The following is a description of a gene set: studied in species Homo sapiens Human Gene Set: GOCC_PERICENTRIC_HETEROCHROMATIN Heterochromatin that is located adjacent to the CENP-A rich centromere 'central core' and characterized by methylated H3 histone at lysine 9 (H3K9me2/H3K9me3)., and this is the list of marker genes: CBX1, DNMT1 (DNA methyltransferase 1), BAZ1B (bromodomain adjacent to zinc finger domain 1B), ATRX, CENPB (centromere protein B), CENPC, BAZ1A, IKZF1 (IKAROS family zinc finger 1), ESCO2 (establishment of sister chromatid cohesion N-acetyltransferase 2), HELLS, EZH2, NCAPD3, KMT5C, POLE3, INCENP, ZNF618, MACROH2A1, SNAI1, CBX3, CBX5, SMARCA5, KDM4A, KDM4D, LRWD1, SIRT6, UHRF2, CENPA, FLYWCH1, CHRAC1, KDM4C